Given this list of marker genes Trim32, Myh15, Myh3, Myh9, Obscn, Myh7, Myh7b, Mybph, Mybpc3, Myh2, Actg2 (actin, gamma 2, smooth muscle, enteric), Myo18b (NCBI Gene Id 74376), Myom1, Myo18a, Myh8, Myh14, Myh10, Myh6, Myh1, Myh11, Myh13, Myh4, Mybpc2 (NCBI Gene Id 233199), here is a description of the gene set: studied in species Mus musculus A supramolecular fiber containing myosin heavy chains, plus associated light chains and other proteins, in which the myosin heavy chains are arranged into a filament. Mouse Gene Set: GOCC_MYOSIN_FILAMENT